Given this list of marker genes SPEN, LAMB2, LUZP1, CASZ1, SALL1, PI4KA, FKTN, SLC19A3, SUPT16H, GAN, UGT1A1, TTN, FRG1, HLA-DPB1, ANTXR1, CCDC174, CRLF1, CLCN7, KMT2D, HLA-DRB1, SELENON, MPZ, IRF4, NLRP3, RAPSN, GNE, CNTNAP1, VCP, GSN, PEX26, MTM1, TNFRSF1A, TGFB1, LMNA, RAD51 (NCBI Gene Id 5888), POMT1, IFNGR1, TBC1D2B, SCN4A, TPM2, ALG14, CA2, PRNP, SYT2, BAG3, MTMR14, SDHAF2, SCO2, CHRNE, UBAC2, SLC18A3, ANGPTL6, LYST, KIF1B, ADA2, LMOD3, SRPX2, SPTBN4, PEX12 (NCBI Gene Id 5193), MYO9A, AKT1, LAMA2, CHCHD10, BICRA, THSD1, MEN1, SHMT2, POLG, POLG2, KLHL40, TUBB6, PLEC, CAPN3, ADCY6, MTOR, WDR26, PEX14, SUCLA2, CHRNA1, BIN1, MMP23B, BMS1, PTRH2, TWNK, SLC39A14, IL23R (NCBI Gene Id 94006), IDH1, LRP5, CHN1, ANKH, SKI, TRPV4, COL6A2, FANCE, SMCHD1, XRCC2, EBF3, TFAP2A, MAD2L2, VAMP1, NF2, TNFRSF11A, PEX5, MEFV, DOK7, IDH2, MTMR2, CDH23, CHRND, COLQ, SDHD, SNAP25, SQSTM1, PEX13 (peroxisomal biogenesis factor 13), BAP1, FANCC, ANO5, GPR101, SNX10, LRP4, ZC4H2, DNM2, CCR1, CHRNB1, UBE2T (NCBI Gene Id 29089), ACTA1, TMEM67, MEGF10, NOD2, SMARCB1, SOST, SMARCE1, CHAT, BTNL2, TGFBR3, KCNAB2 (NCBI Gene Id 8514), ERAP1, GFPT1, PEX16, FANCB, OSTM1 (osteoclastogenesis associated transmembrane protein 1), MGME1, SYNE1, FANCM, RERE, DACT1, ADGRG1, DKK1, UBA1, PLXND1, RAD51C, SPEG, AK9, PTH1R, MYMK, TUBB3, COL12A1, AGRN, TRAF7, HSPG2, NEB, GLE1, FKRP, PTPN11, MYH7, TNFSF11, REV3L, TK2, TFG, TCIRG1, AIP, ITGB4, SLC52A3, TERT, FANCD2, NAXE, IL12A-AS1, BRCA1, SDHC (NCBI Gene Id 6391), NRAS, PEX19, PRKCZ, UBA2, PEX3, SLX4, MYMX, PTEN, RFWD3, CHD7, UBE4B, SGCD, CRYAB, PMP22, BRCA2, KLHL41, SMO, COL13A1, SDHB, SALL4, PUF60, KY, DMPK, CFL2, PEX10, HK1 (hexokinase 1), TPM3, ASAH1, SEMA3E, HLA-DPA1, PALB2, SLC12A6, IL12A, COL3A1 (NCBI Gene Id 1281), ABCB7, ITPR1, YME1L1, C4A, PDPN, BRIP1, DLL4, MYL2, NEFL, DPAGT1, MAFB, ESCO2, RYR1, COL6A1, PEX1, PRDM16, GJC2, STAT4, SUFU, CTLA4, PRTN3, PEX11B, AKT3, MYPN, PEX2, GJA1, ERCC4, LARGE1, SLC52A2, SIX1, POMT2, CRPPA, SLC25A1, SLC5A7, TOR1A, FAS, TLR4, DNAJB6, ABCA1, FANCF, GABRD, SIX5, LRP12, AMER1, MYD88, TRIM32, ADNP, KLRC4, MTRFR, ENG, FANCG, FANCI, PDGFB, PEX6, PTDSS1, KBTBD13, EYA1, SH3TC2, DNASE1L3, HOXB1, PIK3CA, RRM2B, SLC25A4 (NCBI Gene Id 7872), PTPN22, FANCL, CHKB, HMBS, HLA-B (major histocompatibility complex, class I, B), IL10, LMX1B, GMPPB, MUSK, STAG2, DES, ALG2, FANCA, PABPN1, PSAP, here is a description of the gene set: Human Gene Set: HP_ABNORMAL_CRANIAL_NERVE_PHYSIOLOGY A functional abnormality affecting one or more of the cranial nerves, which emerge directly from the brain stem. species: Homo sapiens Abnormal cranial nerve physiology